Given this list of marker genes HCK, PLBD1, PPT1, MCL1, CD93, TNFRSF1B, ADA2, CD302 (CD302 molecule), IFNGR1, NCF2, DUSP1, LILRB2, FCER1G, PSAP (NCBI Gene Id 83009), CASP1, FGL2, CTSS, CHST15, TLR2, MAFB, AIF1, AP1S2, THEMIS2, CFP, NOD2, TLR8, TYROBP, PYCARD, TMEM127, MFSD1, PECAM1, LILRB3, CEBPB, MS4A6A, LILRA6 (leukocyte immunoglobulin like receptor A6), RGS2, RNF130, S100A4, HSD17B11, CYBB, CEBPD, ZFP36 (ZFP36 ring finger protein), LILRA2, LILRA1, FCN1, IGSF6, TYMP, CLEC4A, TBXAS1, CCR1, TCIRG1, LST1, CMTM6, SH3BGRL3, TNFAIP2, ITGB2, here is a description of the gene set: Human Gene Set: GNF2_PECAM1 Neighborhood of PECAM1 platelet/endothelial cell adhesion molecule (CD31 antigen) in the GNF2 expression compendium species: Homo sapiens Neighborhood of PECAM1